Given this list of marker genes ROCK1, SMAD6, GATA5, TGFB1, TNFRSF1B, BMPR2, HEY2, ADAMTS5, PCDHA10, TGFBR2, CDH11, ADAMTS19, NOS3, AXIN2, EFNA1, RB1, RHOA (NCBI Gene Id 387), ROBO1, ROCK2, ELN, GJA5, SOX9, ROBO2, HEYL, SLIT3, HEY1, NKX2-5, EMILIN1, NPPA, SNAI1, TBX20, GATA4 (NCBI Gene Id 2626), SMAD2, JAG1, DLL4, NOTCH2, NOTCH1, TWIST1, SLIT2, SNAI2, TNFRSF1A, NFATC1, STRA6, RBPJ (NCBI Gene Id 51580), BMP2, GATA3, BMP4, TGFB2, TIE1, here is a description of the gene set: Human Gene Set: GOBP_SEMI_LUNAR_VALVE_DEVELOPMENT The process whose specific outcome is the progression of a semi-lunar valve over time, from its formation to the mature structure. species: Homo sapiens